The following is a description of a gene set: Reactome Pathway: Phosphorylation of proteins involved in G1/S transition by active Cyclin E:Cdk2 complexes The G1/S transition is facilitated by Cyclin E:Cdk2-mediated phoshorylation of proteins including Rb and Cyclin Kinase Inhibitors (CKIs). studied in species Homo sapiens part of: Cyclin E associated events during G1/S transition , and this is the list of marker genes: CCNE2, RB1, CDK2, CCNE1